Given this list of marker genes DMC1, DHRS13, XACT, SLC25A15, CPOX, GYPE, PCLAF, EPCAM (epithelial cell adhesion molecule), RHAG, DNAJA4, RHCE, SLC22A4, TSPO2, FAM178B, LONRF3, ABCB10, SLC38A5, SPAG17, KEL, FAM117A, ST8SIA1, SLC25A21, ICAM4, SLC14A1, SLC6A9, HMBS, C17orf99, TESMIN, MYB, GYPB, SLC4A1, C16orf95, SPTA1, ART4, RWDD3-DT, PRSS57, KLF1, KCNH2, ACSBG1, CALN1, ATP13A3-DT, EPB42, SLC29A1, EIF5AP2, ENSG00000260592, EPS15-AS1, TRIM10, IL1RL1, PLPP4, ANK1, E2F2, CDK15, MINPP1, GYPA, TFRC, ACHE, SLC2A14, CDC25A, ERMAP, PRG2 (NCBI Gene Id 87065), HEMGN, PPM1H, HDC (histidine decarboxylase), SLC22A16, TYMSOS, SLC5A4-AS1, EPOR, here is a description of the gene set: The gene expression program underlying the specification of human cell types is of fundamental interest. The study authors generated human cell atlases of gene expression and chromatin accessibility in fetal tissues. For gene expression, the study authors applied three-level combinatorial indexing to >110 samples representing 15 organs, ultimately profiling ~4 million single cells. The study authors leveraged the literature and other atlases to identify and annotate hundreds of cell types and subtypes, both within and across tissues. Our analyses focused on organ-specific specializations of broadly distributed cell types (such as blood, endothelial, and epithelial), sites of fetal erythropoiesis (which notably included the adrenal gland), and integration with mouse developmental atlases (such as conserved specification of blood cells). These data represent a rich resource for the exploration of in vivo human gene expression in diverse tissues and cell types. Human Gene Set: DESCARTES_FETAL_SPLEEN_ERYTHROBLASTS species: Homo sapiens from publication Cao J, O'Day DR, Pliner HA, Kingsley PD, Deng M, Daza RM, Zager MA, Aldinger KA, Blecher-Gonen R, Zhang F, Spielmann M, Palis J, Doherty D, Steemers FJ, Glass IA, Trapnell C, Shendure J (PMID 33184181) Marker genes curated from the annotated cluster as represented in the Descartes Human Gene Expression During Development database.